Given this list of marker genes BIRC3, SLC17A6, ORAI1, TMEM67, ADORA1, MBTD1, MNT, BAIAP2, ABL2, ZBTB46, FNIP1, PIM1, AEN, CCR8, SUCO, TMEM44, SH2D2A, TGIF2 (TGFB induced factor homeobox 2), PHLDA3, LANCL3, DCAF12L1, RARA, TRAF1, SH2B3, IL3, ATXN7, MAPK8IP3, ADGRD1, FOXO1, NDRG1 (NCBI Gene Id 7998), GNPTAB, KBTBD7, SLC25A19, RELA, TRIM42, TUT1 (terminal uridylyl transferase 1, U6 snRNA-specific), KDM2B, UPB1, ZSWIM4, HIVEP1, ZC3H12A, SIDT2, TINF2, VPS37B, CD83, ANKRD17, SARAF (store-operated calcium entry associated regulatory factor), ZSCAN18, TNFRSF10B, TASOR2, BCL2L1, NINJ1, MIR155, ELL2, CISH, ITK, USPL1, ZBTB43 (zinc finger and BTB domain containing 43), SPATA2, CSRNP1, CPD, DHX40, CLK4, ADORA2B, RASA2 (RAS p21 protein activator 2), CCL3, JMJD1C, DNAI7, CD69 (NCBI Gene Id 969), BLCAP, KRTAP5-3, ATG16L2, TUT7 (NCBI Gene Id 79670), CCNL1, MAFG, CCNL2, HERPUD1, PPP2R2A, TNKS, FXYD7, NFKBID, RRAD, DUSP8, PAN3, FBXW9, SIPA1L2, NFKB1, MT2A, ARL5B, FAP, ODC1, PTGER2, TNFAIP3, SIAH2, ICAM1, NR4A3 (NCBI Gene Id 8013), BCL2L11, EPC1, PDCD1LG2, AKAP13, MXI1, ETV3, SPAG9, TOM1, ITGAV, WNK1, RORA, SAFB2, GABARAPL1, SV2C, CXADR, SMOX (NCBI Gene Id 54498), C1QTNF3, CHD2, ADORA2A, MAP3K7, SDCBP2, CD274, SESN2, CLDND2, BTG1, ABTB2, ADARB1 (NCBI Gene Id 104), RNF157, USP31, CLK1, NNAT, PPP1R16B, DGAT1, TTC19, MXD1, RNF149, DUSP4 (NCBI Gene Id 1846), FEM1C, MST1R, NFKBIZ, ADAM9, ATF4, NAB2, TRAF3, PHLDA1, CLIP2, AHI1, ZSWIM6, RHBDD1 (rhomboid domain containing 1), ELAVL3, SIK3, SLC7A1, DUSP2, NR3C1, FGD3, JMY, BRWD1, CCNK, H1-7, DNAJB2, NFAT5, ZFAND2A, DUSP14, ACR, SLC15A3, MIR23B, GADD45B, PLK3, RABGEF1, RELB, USP53, NMD3, here is a description of the gene set: from publication Indraccolo S, Pfeffer U, Minuzzo S, Esposito G, Roni V, Mandruzzato S, Ferrari N, Anfosso L, Dell'Eva R, Noonan DM, Chieco-Bianchi L, Albini A, Amadori A (PMID 17202376) IFNs are highly pleiotropic cytokines also endowed with marked anti-angiogenic activity. In this study, the mRNA expression profiles of endothelial cells (EC) exposed in vitro to IFN-alpha, IFN-beta, or IFN-gamma were determined. We found that in HUVEC as well as in other EC types genes were upregulated (>2-fold increase) by IFNs, including genes involved in the host response to RNA viruses, inflammation, and apoptosis. Interestingly, genes showed a >5-fold higher induction by IFN-alpha in EC compared to human fibroblasts; among them, the gene encoding the angiostatic chemokine CXCL11 was selectively induced by IFN-alpha in EC along with other genes associated with angiogenesis regulation, including CXCL10, TRAIL, and guanylate binding protein 1 (GBP-1). These transcriptional changes were confirmed and extended by quantitative PCR analysis and ELISA; whereas IFN-alpha and IFN-beta exerted virtually identical effects on transcriptome modulation, a differential gene regulation by type I and type II IFN emerged, especially as far as quantitative aspects were concerned. In vivo, IFN-alpha-producing tumors over-expressed murine CXCL10-11, GBP-1 and TRAIL, with evidence of CXCL11 production by tumor-associated EC. Overall, these findings improve our understanding of the anti-angiogenic effects of IFNs by showing that these cytokines trigger an anti-angiogenic transcriptional program in EC. Moreover, we suggest that quantitative differences in the magnitude of the transcriptional activation of IFNresponsive genes could form the basis for cell-specific transcriptional signatures. Genes up-regulated fibroblasts: untreated versus interferon alpha. studied in species Homo sapiens Human Gene Set: GSE3920_UNTREATED_VS_IFNA_TREATED_FIBROBLAST_UP